The following is a description of a gene set: The ability of dendritic cells (DCs) to activate immunity is linked to their maturation status. In prior studies we have shown that selective antibody-mediated blockade of inhibitory FcgRIIB receptor on human DCs in the presence of activating immunoglobulin (Ig) ligands leads to DC maturation and enhanced immunity to antibody-coated tumor cells. Here we show that Fcg receptor (FcgR) mediated activation of human monocytes and monocyte-derived DCs is associated with a distinct gene expression pattern, including several inflammation associated chemokines as well as type 1 interferon (IFN) response genes including the activation of signal transducer and activator of transcription 1 (STAT1). from publication Dhodapkar KM, Banerjee D, Connolly J, Kukreja A, Matayeva E, Veri MC, Ravetch JV, Steinman RM, Dhodapkar MV (PMID 17502666) Genes down-regulated in response to anti-FcgRIIB: dendritic cells versus monocytes. Human Gene Set: GSE7509_DC_VS_MONOCYTE_WITH_FCGRIIB_STIM_DN species: Homo sapiens, and this is the list of marker genes: MYL12A, CCR1, AXL, OAS2, SRSF4, RNF144A, CCL2, MTMR6, TGM1, CGGBP1, CNTN1, SSTR2, HCK, ELF4, SLC31A2, ETV6, TRIM25, B4GALT5, ABTB2, RERE, TNFRSF1A, ADPRH (NCBI Gene Id 141), APOBEC3G, USPL1 (ubiquitin specific peptidase like 1), ADM, ARHGAP25, KRT76, RBCK1, TOP1, SASH1, LAG3, IFIT1, SETD1B, LYN, FAS, SP110, CEACAM1, TRAFD1, CSTF3, IFIT3, HIVEP2, XAF1, TLK2, ASCL2, CASP10, BAK1, PPP4R1, ACSL1, NAMPT, IFITM3, DIO3, CXCL11, DYNLT1 (dynein light chain Tctex-type 1), SSB, STRN (striatin), SFT2D2, ABL2, IGF2BP3, RAB14, LILRB1, DUSP6, CTNS, ZFP36, RSAD2 (radical S-adenosyl methionine domain containing 2), RTCB, LINC03124, IFITM1, DHX34, OAS1, NASP, SLC10A1, MYO1B, SP100, LGALS9, H3-3B, EIF4G3, MACF1, KBTBD2, RBMS1, RABGAP1L, ATF6, AKR1C4, SRGAP2, MFN1, STK17B, LRRC42 (NCBI Gene Id 115353), FBXO7, HEG1, BLTP1, ENPP2, NECTIN2, RUBCN, RNF19B, TRIM38, ZNF200, RGL1, RIF1, IFI35, NUP62, CCL13, GCA, BMPR2, RIPK1, IFI44L, CCL7, TWF1, BRCA2, DACH1, LMNB1, PLSCR1, RALB, IRF9, PLN, RBPJ, MX2, TRIM21, PPP2R2A, IL6, ATG12, EED, RBBP6, NAPA (NSF attachment protein alpha), MALT1, FPR2, IRF7, DNAJA1, STBD1, DHX15, TENT4A, ZC3HAV1, SOCS1, ZNF207, IL7, AMD1, IFIT2, CD86, CCSER2, XIAP, FZD2, P2RY6, LCP2, THEMIS2, LMO2, CDK17, IFI44, LIG4, S100G, PSMA4, ISG15, BARD1, RBM34, CD2AP, FUT4, GRIK2, ARAP2, CKAP4, ANKS1A, ARID5A, SMAD3, STIMATE, TRIM14, BAZ1A (bromodomain adjacent to zinc finger domain 1A), EVPL (NCBI Gene Id 2125), BST2, LAMP3, ARF6, RIN2, CMTR1, TDRD7, SERPINB1, MX1, OASL, CHSY1, UBE2S, PPFIBP1, DRAP1, HIRA, GTF2B, CCL8, ST3GAL5, PTPN2, N4BP1, ISG20 (NCBI Gene Id 3669), PPP3CC, NRIP1, RASGRF1, NDRG2, SBNO2, CLDND1, TOR1B, STAT2, BIRC2, ATF3, ADAR, CACNA1A, CXCL9, MEIS3P1